Given this list of marker genes Mtfr1l, Zfp597 (NCBI Gene Id 71063), Pias2, Kctd20, Gpnmb (NCBI Gene Id 93695), Galr1, Ireb2, Tcf7l2, Epb41l1, Lonrf3, Daw1, Abhd5, Glis3, Usp42, Nlrp12, Zfp354a, Rarb, Clvs1, Agpat5, Zc2hc1a, Ryr3, Phf8l, Skint3, Zfp608, Ewsr1, Nanos2, Gpr173, Trak1, Hdac9, Umodl1, Pdk3, Tsc22d3, Malrd1, Plekha3, Dcc, Tom1l2, Arhgap42, Tspan33, Pde3b, Ccdc178, Slc39a9, Zfp951, Tmeff1, Fndc3a (fibronectin type III domain containing 3A), Cdc37l1, Tpk1, Psg21, Dtx3l, Tigd3, Zfp696, Vstm2a, Fn3krp, Map1b, Sulf2, Srek1, Nol3, Max, Tcf20, Zwilch, Ccr3, here is a description of the gene set: studied in species Mus musculus Genes predicted to be targets of miRBase v22 microRNA mmu_miR_12191_3p in miRDB v6.0 with MirTarget v4 prediction scores > 80 (high confidence targets). from publication Chen Y, Wang X (PMID 31504780) Mouse Gene Set: MIR_12191_3P